The following is a description of a gene set: studied in species Homo sapiens Human Gene Set: REACTOME_TRANSPORT_TO_THE_GOLGI_AND_SUBSEQUENT_MODIFICATION Transport to the Golgi and subsequent modification, and this is the list of marker genes: SEC22B, TUBA1B, TUBA3D, TUBA1C, SEC24D, TRAPPC10, CNIH2 (NCBI Gene Id 254263), GOSR1, KDELR3, MGAT2, ST3GAL4, TRAPPC1, ARFGAP1, B4GALT2, MGAT3, SPTBN5, SEC13, CHST8, SCFD1, TFG, SPTB, TUBB2B, F5, TRAPPC9, TUBA8, SEC22A, SEC22C, TRAPPC6A, TRAPPC4, SEC24C, SPTAN1, BET1L, SEC24A, ACTR1A, FUT3, ANK2, LHB, CAPZA1, TUBB8B, COPA, CSNK1D (NCBI Gene Id 1453), CGA, SEC23A (NCBI Gene Id 353367), DCTN2, TUBA1A, SPTBN2, FUCA1, DCTN4, F8, MAN2A1, SPTBN1 (NCBI Gene Id 91654), COPG2, ARF1, MANEA, MAN1A2, SPTA1, DCTN5, DCTN6, MAN1A1, COL7A1, SEC24B, LMAN1, TUBA4A, COPZ1, MIA3, GOLGB1, DYNC1H1, B4GALT3, COPE, TMEM115, TRAPPC3, MGAT5, B4GALT1, TRAPPC2L, DYNC1I2, LMAN2L, ST8SIA3, COPB1, COG4, SEC31A, FOLR1, NAPG, LMAN1L, DYNLL1, GORASP1, MGAT4B, PREB, NSF, NAPA, PPP6R3, CTSC, COG1, BET1, KDELR1, TRAPPC5, LMAN2, SAR1B (NCBI Gene Id 56680), ST8SIA6, ARF4, DYNC1LI1, PPP6C, COG6 (NCBI Gene Id 57511), ARF3, ANKRD28 (ankyrin repeat domain 28), AREG, TUBA3E, CAPZA3, KDELR2, GBF1, CAPZA2 (NCBI Gene Id 830), ANK1, COG8, CD55, USO1, B4GALT5, CHST10, CNIH3, TRAPPC2, SEC16A, RAB1B, TUBA3C, TUBB3, ARF5, TUBB2A, TUBB6, ANK3, MIA2, B4GALT6, NAPB, TMED3, TUBB1, GOSR2, SEC23IP, DCTN1, COG7 (component of oligomeric golgi complex 7), COG5, DYNLL2, TRAPPC6B, STX5, TUBA4B, INS, CAPZB, YKT6, STX17 (NCBI Gene Id 9485), TUBB8, DCTN3, SPTBN4, DYNC1LI2, ARFGAP3, TMED10, ARCN1, ARFGAP2, CTSZ, DYNC1I1, COPZ2, MAN2A2, RAB1A, B4GALT4, SEC16B, TMED9, MGAT4A, COG3, TMED2, TUBAL3, TMED7, CD59, TGFA, ST6GAL1, ST8SIA2, FUT8, TBC1D20, CNIH1, MCFD2, PPP6R1, COPG1, GRIA1, COPB2, TUBB4B, COG2, GOLGA2, SERPINA1, ACTR10, MGAT1, MAN1C1, TUBB4A, SEC31B (NCBI Gene Id 25956), MGAT4C